The following is a description of a gene set: Genes predicted to be targets of miRBase v22 microRNA mmu_miR_6349 in miRDB v6.0 with MirTarget v4 prediction scores > 80 (high confidence targets). from publication Chen Y, Wang X (PMID 31504780) species: Mus musculus Mouse Gene Set: MIR_6349, and this is the list of marker genes: Man2b1, Rgs19, Eif1ax, Pla2g4a, Spred1, Kctd10, Fndc3a, Mpp7, Pde7a, Cask, Bsn, Bach2, Foxp1, Sri, Tppp, Mapkbp1 (NCBI Gene Id 99332), Rbm27, Zfp280d (zinc finger protein 280D), Tex11, Rnf138, Nrp1, Arap2, Nfatc3, Grk6, Neto1, Zfp36l2, Gpr158, Utrn, Gpd2, Rabgap1l (RAB GTPase activating protein 1-like), Tbc1d15, Cdk6, Hycc1, Prkacb, Snai2, Xpo6, Osbpl7, Arfip1, Pdcd10, Eva1a, Slc25a22, Miga2 (mitoguardin 2), Atxn1l, Anxa2, Hmbox1, 4930563E22Rik, Ccr1l1, Alkal2, Marchf1, Mal2, Bltp3b, Ddx5, D6Wsu163e, Thbs1, Atf2, Ube2h, Fndc3b, Bcl11a, Map4k3, Coro1c, E2f5, Cited2, Ndrg1, Pik3c2a, Sprn, Cfap47, Cd2ap, Sox17, Nfatc2 (nuclear factor of activated T cells, cytoplasmic, calcineurin dependent 2), Adpgk, Ttc7b, Ap1s1, Lasp1, Ywhaz, Zc3h7b, Srsf9, Arf4, Adgra3, Azin1, Atp6v1a, Nol4l, Tra2b, Zfp800, Spire1, Folr1, Phyhip, Col25a1, Ets1, Ajuba, Pdik1l, Ppp4r2, Trappc3, Ube4a, Fnip2, Ust, Jade3, Max, Caap1, Phax, Suz12, Larp4 (NCBI Gene Id 52147), Ndrg3, Ppib (peptidylprolyl isomerase B), Eml3, Fbxo33, Hinfp, Timp3, Sec22b, Mecom (MDS1 and EVI1 complex locus), Sulf1, Kalrn, Peak1, Setbp1, Snx2, Smarcb1, Cndp1 (carnosine dipeptidase 1), Slc38a3, Sema6d (NCBI Gene Id 98780), Elf1, Pbx1, Vamp2, Phf6, Cttnbp2nl, Sec61a1, Hmcn1, Tmem178, Josd1, Fn1, Ccdc166, Arhgap25, Nexmif, Nedd9, Nlrp4e, Dph6, Prkce (NCBI Gene Id 98094), Stag2, Nxph2, Ywhab, Tmcc1, Hacd3, Sash1, Tspyl4, Arf3, Esp34, Gclc, Wars2, Adar, Hipk3, Plppr4, Lrrc8a, Crem, Myocd, Cmpk2, Tmem243, Dlg1, Obsl1, Map1a, Cdc14a, Tmem18, Hmgn1, G6pdx, Syn3, Tmsb4x, Wdr48, Slc37a3, Igf1, Pgrmc1, Trim2, Ank3, Mtx1, Edn1, Tex2, 9230112D13Rik, Twf1, Usp33, Cebpz, Hsp90b1, Mylk, Rnf145, Pirt, Smarcc1, Kank4, Rictor, Thoc2, Ip6k2, Dnajc6, Glce, Eeig1, Kif2a, Nol3, Trappc4, Prr14l, Glcci1, Matr3, Creb5, Mctp1, Entpd7, Zfp661, Lrch1 (leucine-rich repeats and calponin homology (CH) domain containing 1), Hs3st3b1, Ncoa1, Pax3, Helz2, Thrb, Mex3c, Ms4a7, Tnpo2, Tspan4, Sp2, Gja1, Ktn1, Srgap2, Nup50, Git1, Stmn2, Stard7, Ankrd29, Serp1, Atg13, Serpinf1, Fam168a, Kcnip3, Sec63 (SEC63 homolog, protein translocation regulator), Smim14 (NCBI Gene Id 71403), Rit2, Tpm3, Glis2, Slc39a10, Wbp1l, Dennd6a, Ptprg, Dach1, Kcnd3, Unc119b, Cav2, Ncl, Tars2, Fcgr4, Clock, Adprm (ADP-ribose/CDP-alcohol diphosphatase, manganese dependent), Clcn3, Pax7, Frmd3, Knop1, Mon2, Zfp740, Tnks2, Mmd, Asxl3, Rrm1, Scaf11, Cnn3, Raver2, Mfsd14a (NCBI Gene Id 15247), Dach2, Slc25a25, Mmd2, 1700066M21Rik, Bdnf, Actb, Hnrnpu, Stk39, Dgke, Klf4 (NCBI Gene Id 269540), Pip4p1, Prlr, Msantd2, Cped1, Ccsap, Kmt2e, Phip, Kat6a, Gnpda2, Hspd1, Tgfbr3, Cdk14, Cbl, Syt1, Ubr5, Frs2, Ss18, Chsy1, Plxna4, Tbp, Yipf4, Slc25a53, Rnf150, Stc2, Meox2, Arcn1, Slc29a3, Tpm4, Zfp40, Rfesd, Wnt3, Cap1, Nxt2, Wnk3